The following is a description of a gene set: studied in species Mus musculus A motor activity that generates movement along a microtubule toward the plus end, driven by ATP hydrolysis. Mouse Gene Set: GOMF_PLUS_END_DIRECTED_MICROTUBULE_MOTOR_ACTIVITY, and this is the list of marker genes: Kif1a, Kif15, Kif18a, Kif5c, Kif19a, Kif17, Kif18b, Kifc2, Kif1c, Kif11, Kif1b, Kif5a, Kif16b, Kif5b (kinesin family member 5B), Kif21a, Kif20b, Kif14